Given this list of marker genes Gnb3, Epgn, Gng5, Gng7, Mmp7, Mmp2, Strn, Gng11, Shc1, Gng3, Hras, Tgfa, Ptk2, Gngt2, Zdhhc21, Cav1, Pik3r2, Gng4, Cav2, Mmp3, Esr2, Gngt1, Gng10, Cdkn1b, Egfr, Gnai1, Gnb5, Gnb2, Zdhhc7, Calm1, Esr1, Pdpk1, Hspb1, Gng8, Xpo1, S1pr3, Gnat3, Areg, Btc, here is a description of the gene set: This event has been computationally inferred from an event that has been demonstrated in another species.<p>The inference is based on the homology mapping from PANTHER. Briefly, reactions for which all involved PhysicalEntities (in input, output and catalyst) have a mapped orthologue/paralogue (for complexes at least 75% of components must have a mapping) are inferred to the other species. electronically inferred by orthology from the curated human pathway studied in species Mus musculus part of: ESR-mediated signaling Reactome Pathway: Extra-nuclear estrogen signaling